Given this list of marker genes MAPK10, UBQLN2, TMPO, HNF4G, ARFGAP3 (NCBI Gene Id 26286), HOXD3, SOSTDC1, SLC1A3, CNPPD1, SNRNP200, GPM6B, MFHAS1, CDYL2, ODC1, DHX32, SCNN1G, PRDX1, NHLH2, GJC1, POMGNT1, AFF3, NSUN6, ARL8B, SYNCRIP, RBPJ, TSHZ1, MAP3K1, CROT, LLGL2, SNAP25, HES1, DEPDC4, USH2A, DPY19L4 (dpy-19 like 4), PPP2R5E, PPHLN1, ESRP1, GINS1 (GINS complex subunit 1), ZNF350, DNAJC5, MZT1, GPATCH2L, SRSF1, HYKK, DLGAP1, ANP32E, ATOH7, KCNMA1, TFDP2 (NCBI Gene Id 7029), AK3 (NCBI Gene Id 50808), PPIP5K2, NSD2, LTBP1, TXLNG, CLPX, DISC1, PDE4D, DTNA, NUFIP2 (nuclear FMR1 interacting protein 2), MAN1A2, PTPRZ1, PDE1C, TMEM220, PDXDC1, GLCCI1, UHRF1 (ubiquitin like with PHD and ring finger domains 1), UBE3A, EOLA1 (endothelium and lymphocyte associated ASCH domain 1), AMMECR1L, SEPTIN14, PIWIL4, TRIM13, PURB, SIRT1, SCN9A, ANKRD18A, ZNF292, EGFLAM, FRS2, COL19A1, FLVCR1, BBX, PLEKHH3, SLC26A7, EPSTI1, TMEM132C, CALHM4, AAGAB, RUNX2, KAT6A, ACOT13, PWWP2A, MAGOHB, ADD1, TCF4, CBL, STXBP5, EFNB1, ANKRD13A, CANX, PPP1R2, ADIPOR1, SRC, DDX52, SEPHS1, SCAMP1 (secretory carrier membrane protein 1), ZNF277, UBE2L3, NAMPT, ZNF385B, GVQW3, RDX, DCK, RBM47, GAB1, C16orf54, IRAK2, MAPKAP1, SCML2, NPAS3, SPIN2B, RAG1, FBXL17, SOX1, KDM7A, SNX18, CMTM4, NAB1, SYT1, DIRAS2, CITED2, KIAA1671, AK7, METTL9, EIF3A, SULT4A1, HS2ST1, ADAMTSL5, DPYSL4, CREB3L2, BRINP3, DACH1, PHLPP1, SPIN2A, PDZD4, STXBP6, SLC35B4, QKI, CYB5D1, PCMTD1, TPST1, SERAC1, LRCH4, FMN2, SECISBP2L, MTA1, PSMG1, LUC7L, TMTC2, SHISA6, PTN, KLHL36, ENAH, SLC25A12, SLITRK2, ATP2A2, THSD7B, SORCS1, CEBPD, SLC13A1 (solute carrier family 13 member 1), HDX, PLCXD1, HPSE, ACTL6A, NCOA2, WAC, SOX8, TLL1, C3orf52, PI4K2B, TMEM50B, EGF, USP25, GABRA1, PTPRK, ZDHHC13, IGF2BP3, LGSN, NUDT11, OLFML2B, IPP, TCTN2, RRAGD, HNRNPM, H2BC21, FAM220A, SLC35F1, FANCE, ETNK1, MRPL19, BRD1, ATAD2B, MDM1, A1CF, SUFU, NWD1, CPSF6, SASH1, CPEB2, UTP20, ERBB4, TMTC1, GPATCH8, ACACA, PTPRC, SCN5A, CDK11A (NCBI Gene Id 986), MLLT10, PRRG4, DNAJB7, PSMA5, SEH1L, ADIPOR2, SLC4A7, NEUROG1, ABHD5, ZNF22 (NCBI Gene Id 7570), MTSS1, MAP7, RECQL, PPFIBP1, UBR5 (NCBI Gene Id 51366), MTFMT, ATXN7L1, SBF2, ST18, TUT7, FAM53B, MSI2, PTPRB, MEF2A, TMEM273, TMEM47, SATB1, SPATS2L, SULF2 (NCBI Gene Id 55959), ERLIN2, KMT5A, PCNP, LVRN, SKIC8, LRBA, SDE2 (SDE2 telomere maintenance homolog), NCOA3, BMI1, THSD7A, TRABD2B, CDC42BPB, FZD3, BMPR2, XPOT, RFX3, ZMYM2, ZCCHC24, STON1, COIL (coilin), MFF, ZFHX4, PHF6, CDON, AKIRIN2, NSL1, SRD5A1, SCAI, IER5, CLASP1, NEDD4, CDC40, PTGFR, TPD52L3, SOX11, BZW1, PTPN14, APELA, ZNF451, ADGRG2, ATXN2, OSBPL10, ALG1 (NCBI Gene Id 56052), EBF3, TOR1B, ZNF714, C16orf46, KHDRBS2, FAM200B, KIF3A (NCBI Gene Id 11127), PCBD2, PEX2, SLF2, DTD1, CNTLN, SLC35F5, CELF2, UNC50, SIAH1, NIPBL, KLRC4, ANKRD10, PTP4A1, GASK1B, GAGE1, CDKAL1, CD200, FOXC1, U2SURP, UBR7, DNAJC6, BRPF3, PIGC, PIP4P2, DEPDC5, CSTF3, SORD, PRDM1, IGFBPL1, FTMT, MECP2, RFPL4B, PRLR, TMEM170A, TTC14 (tetratricopeptide repeat domain 14), HP1BP3, TMEM33, MYO1D, SRSF6, FUNDC2, DLL4, CFAP20DC, MSANTD2, RAI14, CDH2, PGRMC2, RAD1, NCOA5, FGD2, SLC26A3, DUSP10, EIF5A2 (eukaryotic translation initiation factor 5A2), OXR1, APBB2, GNAQ, XPO5, CASZ1, JAZF1, DMXL2, BRWD1, SALL4, PTPRR, SENP7, TGFBR1, AHI1, CDC7, INO80D, CPEB4, BEND4, ELF1, NAT8L, PDZRN3, PPP2CA, NPTX1, DKK2, PPP1R26, UBE2R2, ORAI3, TMED7, GNB4, POLR3C, PHC3, OLR1, SOD2, ZZZ3, PPA1, NPY1R, LINGO3, CHST9, ITPKB, REDIC1, RAB8B, ARID4B, FUT9, BCL2L11, RAP2A (RAP2A, member of RAS oncogene family), PIKFYVE, ZNF326, EFR3A, COMMD3-BMI1, GK5, PPP4R2, POLR2B (RNA polymerase II subunit B), SGIP1, DSG2, ATF7IP, CTF1, CDH11, TMEM200A, MMGT1, TEAD1, FRY, MEF2C, SP4, TUSC2, KLF11, MAFF, PPM1D, GPI, DNMT3B, HSPA1B, SCML1, EFHC1, ARHGEF26, ETV5, CDC42EP3, SMOC2 (SPARC related modular calcium binding 2), ABHD3, KCNA1, RASAL1, SYS1, KBTBD6, UGT2B10, SDC2 (NCBI Gene Id 6383), NXF1, SEC62, COL24A1 (NCBI Gene Id 255631), NCAM1, STARD4, NCBP3, FBXO22, NEDD9, DMP1, HIF3A, ZNF84, SBNO1, BAG4, HOXA2, TBC1D15, WDR35, RORB, KCNK1, MSTN, RBM46, GNE, PSPC1, ATP2B1 (ATPase plasma membrane Ca2+ transporting 1), IL12RB1, RBBP6, DNTTIP1 (deoxynucleotidyltransferase terminal interacting protein 1), FGF14, NOG, ACVR2B, SIPA1L1, MAPK8, FUT10, CCND1, SLC5A3, DAPK1, VGLL3, ENSG00000236754, DNA2, SNRNP48, FAT3 (FAT atypical cadherin 3), ST8SIA1, SPIN1, PDK3, RBM25, SON, FAT4, MBNL2, TCF7L1, here is a description of the gene set: from publication Chen Y, Wang X (PMID 31504780) studied in species Homo sapiens Human Gene Set: MIR1283 Genes predicted to be targets of miRBase v22 microRNA hsa-miR-1283 in miRDB v6.0 with MirTarget v4 prediction scores > 80 (high confidence targets).